Given this list of marker genes CEBPB, JUNB, ZAP70, TNRC6C, STAT3, AGO2, AGO4, RB1, NPM1, CUL1, STAT5A, FOXM1, TWIST1, BCL2A1, MAPK1, MIR21, DNMT1, PRF1, RPS6, SKP1, NOTCH1, HDAC1, AGO1, AGO3, RBX1, CCNB1 (NCBI Gene Id 891), MECP2 (NCBI Gene Id 8274), MAPK3, GZMB, IL10RA, ZC3HC1, PTPN6, IRF4, ICOS, MOV10, here is a description of the gene set: studied in species Homo sapiens Human Gene Set: REACTOME_NUCLEAR_EVENTS_STIMULATED_BY_ALK_SIGNALING_IN_CANCER Nuclear events stimulated by ALK signaling in cancer